Given this list of marker genes FKBP7, FKBP1A, FKBP5, FKBP2, FKBP6, NFATC1, FKBP1B, FKBP4, FKBP3, FKBP10, here is a description of the gene set: Human Gene Set: GOMF_FK506_BINDING species: Homo sapiens Binding to a 23-membered macrolide lactone FK506.